Given this list of marker genes Gm4117, Ap3b1, Gm26927, Gm31630, Serinc5, Fam151b, Gm4130, Zcchc9, Gm19239, Gm46389, Gm4936, Gm4076, A230107N01Rik, Gm32089, Gm5452, Mblac2, Atp6ap1l, Gm4211, Homer1, Gm5668, Tent2, Gm17259, Gm5199, Vcan, Gm24737, Gm15622, Thbs4, Bhmt2, Snord138, Rasgrf2, Gm2076, Xrcc4 (NCBI Gene Id 71945), Gm29680, 1700119I11Rik, Cmya5, Arsb, Gm24507, 2310067P03Rik, Gm4066, Gm32305, Gm4241, Msh3, 9330111N05Rik, Gm4059, Gm8546, Gm22778, Mir5624, Gm9776, Polr3g, Gm18265, A630019I02Rik, Mir3961, Gm24295, Lhfpl2, Scamp1, Gm18518, Atg10, Gm6411, Gm46432, Gm8526, Gm19139, Zfyve16, Gm46396, Gm5666, Lysmd3, Ssbp2, Rasa1, Gm5667, Gm17750, Dmgdh, Jmy, Gm6109, Rps23, Cetn3, Ccnh, Adgrv1, Edil3, Bhmt, 5430425K12Rik, C030017D09Rik, Ckmt2, Hapln1, Gm30155, Gm8399, Gm34585, Dhfr, Gm21232, 4833422C13Rik, Gm8447, Gm17450, Tmem167 (transmembrane protein 167), AW495222, Spz1, Gm8456, Mir9-2, Gm18960, Gm18517, Cycs-ps3, Cox7c, A830009L08Rik, Gm4814, Gm16318, Mir9-2hg, Gm4813, Gm20379, Ankrd34b, F830210D05Rik, Tmem161b, Mef2c (myocyte enhancer factor 2C), Acot12, Mtx3, Gm33366, here is a description of the gene set: species: Mus musculus Mouse Gene Set: chr13C3